The following is a description of a gene set: from publication He P, Lim K, Sun D, Pett JP, Jeng Q, Polanski K, Dong Z, Bolt L, Richardson L, Mamanova L, Dabrowska M, Wilbrey-Clark A, Madissoon E, Tuong ZK, Dann E, Suo C, Goh I, Yoshida M, Nikolić MZ, Janes SM, He X, Barker RA, Teichmann SA, Marioni JC, Meyer KB, Rawlins EL (PMID 36493756) studied in species Homo sapiens AT1 Human Gene Set: HE_LIM_SUN_FETAL_LUNG_C1_AT1_CELL, and this is the list of marker genes: TUBB6, IL18, ABCA8, ICAM4 (NCBI Gene Id 3386), ADIRF, CRYAB, COL4A3 (NCBI Gene Id 200750), PLLP (plasmolipin), HTRA1, COL8A1, ANXA1, SLC39A8, MMP28, ALDH3B1, SUSD2, CAVIN1 (NCBI Gene Id 284119), SFTPD, FAM20A, NRP2, CLIC5, STOM, SEMA5A, EHD2 (NCBI Gene Id 30846), BANCR, ITGB6, ST6GALNAC5, CAV2, AQP5, PHACTR1, MSLN, CYBRD1, TGFBI, RIN2 (Ras and Rab interactor 2), KRT4, NMU, ICAM1, PKDCC, COL4A4, FILIP1 (NCBI Gene Id 27145), SLC2A3, ABCA1, UPK3B